The following is a description of a gene set: studied in species Mus musculus RHOQ GTPase cycle Mouse Gene Set: REACTOME_RHOQ_GTPASE_CYCLE, and this is the list of marker genes: Fnbp1, Plekhg3, Diaph3, Gopc, Arhgap21, Cftr, Iqgap1, Prex1, Arhgap17, Arhgap1, Lamtor1, Itsn1, Arhgap35, Git2, Arhgap26, Srgap2, Snap23, Cdc42ep4, Gfod1, Wwp2, Arhgap33, Obscn, Pak1, Syde1, Scrib, Cdc42bpb, Slc1a5, Jup, Iqgap3, Cdc42bpa, Trip10, Ophn1, Arhgap32, Slc4a7, Cpne8, Pak4, Cav1, Dlc1, Cdc42ep2, Depdc1b, Cdc42ep3, Tfrc, Steap3, Stom, Vangl1, Mpp7, Arl13b, Arhgef9, Cdc42, Arhgap5, Git1 (NCBI Gene Id 63992), Rab7, Gja1, Cdc42ep1, Rhoq, Arhgef7, Pak2, Vamp3